The following is a description of a gene set: Any process that modulates the frequency, rate or extent of synaptic vesicle priming. Synaptic vesicle priming is the formation of SNARE-containing complexes, bringing synaptic vesicle membrane and plasma membranes into close proximity and thereby facilitating membrane fusion. species: Homo sapiens Human Gene Set: GOBP_REGULATION_OF_SYNAPTIC_VESICLE_PRIMING, and this is the list of marker genes: NAPB, SYP, UNC13B, OSBPL2, STX1A, BRSK1, STXBP5, STX1B, STXBP1, NAPA, SYNGR3